Given this list of marker genes NDUFS6, POLR2I, PEX19, MAFG, IRF1, ATP6V1G1, HADHA, SEM1, NDUFS3, DPP4, ATP5F1E, UQCRB, CCNG1, NDUFB3, IGF2BP3, FN1, NDUFS4, CEBPB, ATP5ME, EEF1A2, PPL, ATP6V0C, NDUFS8, RBPJ, NDUFC1, CRYZ, ATP6V0B, NDUFV1, NDUFV2, RPL15, TXNL1, ALDH7A1, YBX1, ATP5MF, NDUFS5, PGRMC1, ATP6V1B2, BTF3, CDH3, UQCRC2, PRKAR1A, TPI1 (NCBI Gene Id 7167), ATP5F1B, GLB1, TRPC1, CRAT, POLR2F, NDUFB5, PPA1, here is a description of the gene set: studied in species Homo sapiens Human Gene Set: MODULE_363 Genes in the cancer module 363.